The following is a description of a gene set: Any process that activates or increases the frequency, rate or extent of the introduction of a phosphate group to a tyrosine residue of a STAT (Signal Transducer and Activator of Transcription) protein. Mouse Gene Set: GOBP_POSITIVE_REGULATION_OF_TYROSINE_PHOSPHORYLATION_OF_STAT_PROTEIN studied in species Mus musculus, and this is the list of marker genes: Lif, Tnf, Il31ra, Ccl5 (NCBI Gene Id 20304), Csf2, Tnfrsf18, Isl1, Hpx, Il23a, Hes5, Cd40, Il12a, Il15, Il18, Kit, Lck, Hdac2 (histone deacetylase 2), Tnfsf18, Osm, Il12b, Cntf, Osbp, Il13, Hsf1, Pecam1, Il2, Clcf1, Il6ra, Il21, Il4, Crlf1, Ifng, Il6st, Jak2, Il3, Arl2bp, Lep (leptin), Il6, Igf1, Erbb4, Ptger4, Epo, Csf1r, Parp14, Pibf1, Ctf1, Hes1, Fyn, Tnfrsf1a, Parp9, Il24, Fgfr3